Given this list of marker genes TREX1, UMOD, CFB, CPT2, PKD1, HPRT1, NT5E, INVS, ELP1, SEC61A1 (NCBI Gene Id 83289), WDR19, CFHR3, ALG9, SLC4A1, FLT1, AVPR2, C1GALT1C1, CLDN16, CD46 (NCBI Gene Id 4272), GAMT, CFHR1, SLC22A12, CFH, HNF1B, DBH, GRHPR, MLIP, FAN1, DNAJB11, IFT56, CC2D2A, CCND1, ALG8, CTNS (NCBI Gene Id 1497), COQ7, SLC41A1, IFT140, APRT, PKD2, MRPS7, SLC4A2, TMEM260, NPHP1, THBD, C3, HBB, NFE2L2, PAX2, GANAB, ALG5, LMNA, CFI, EHHADH, STOX1, ADAMTS13 (ADAM metallopeptidase with thrombospondin type 1 motif 13), MUC1, BICC1, GALNT2, CORIN, COQ4, here is a description of the gene set: Human Gene Set: HP_ABNORMAL_CIRCULATING_CREATININE_CONCENTRATION Abnormal circulating creatinine concentration species: Homo sapiens An abnormal concentration of creatinine in the blood.